Given this list of marker genes CTBS, GNPDA1, CHIT1, OVGP1, AMDHD2, CHIA (NCBI Gene Id 27159), CHI3L1, NAGK, CHI3L2, GNPDA2, here is a description of the gene set: The chemical reactions and pathways resulting in the breakdown of glucosamine-containing compounds (glucosamines). species: Homo sapiens Human Gene Set: GOBP_GLUCOSAMINE_CONTAINING_COMPOUND_CATABOLIC_PROCESS